Given this list of marker genes ITIH3, CDC37L1, TIMP3, ITIH4, ECM1, CTSW, SELENOP (selenoprotein P), SERPINA4, APOH, CLEC3B, RARRES2, LGALS3BP, FAM3C, SPP2, here is a description of the gene set: The volume enclosed by the membrane of the platelet dense granule. studied in species Homo sapiens Human Gene Set: GOCC_PLATELET_DENSE_GRANULE_LUMEN